Given this list of marker genes PARK7 (NCBI Gene Id 113880), SPATA2, VCP, MARCHF6, NHERF4, SART3, SELENOS, RAD23A, SUMO1, SYVN1, PRKN, AMFR, HDAC3, PTEN, CLTC, CHMP3, DERL1, LCOR, BAG6, here is a description of the gene set: studied in species Homo sapiens Binding to a ubiquitin-specific protease. Human Gene Set: GOMF_UBIQUITIN_SPECIFIC_PROTEASE_BINDING